The following is a description of a gene set: Axial hypotonia Human Gene Set: HP_AXIAL_HYPOTONIA Muscular hypotonia (abnormally low muscle tone) affecting the musculature of the trunk. species: Homo sapiens, and this is the list of marker genes: TARS2, AP3B2, GPHN, RNU7-1, PEX14, GRIA3, UNC80 (NCBI Gene Id 84540), ARX, SEPSECS (Sep (O-phosphoserine) tRNA:Sec (selenocysteine) tRNA synthase), UBE3B, UFC1, MICOS13, CEP85L, NSUN2, CAMLG, SLC6A9, MKS1, CERT1, MAN2B1, GM2A, SPTSSA, NDUFV2, PAM16, SLC19A3, PI4K2A, TNR, FGF12, TMTC3, PCBD1, CACNA2D2, GFM2, GCSH, NFIX, DCX, AMPD2, ASNS, ATAD3A, UBA5, ASCC3, SLC6A8, DISP1, TSEN34, PRUNE1, EIF2S3, RNU12, DDX6, GRM7, SLC6A3, GRIN2B, GFER, DLL1, CDON, ADCY5, CACNA1G, TH, POGZ, ADARB1, BRAT1, TUBB3, MED11, PCDH12, CAMK2A, PLP1, RAB18, TUBB4A, EIF2AK2, CRIPTO, MMACHC, PGAP1, OSTM1, HIKESHI, RYR1, NONO, OCLN, MINPP1, GRM1, PDE10A, ARV1, FARSB, EXOSC9 (exosome component 9), SLC31A1, DDC, DHDDS, NDUFA6, DNM1L, PDHX, GLI2, EXOSC3, ABCC8, PTPN23, VAMP2, PRDM13, ALG11, GAD1, TEFM, HEXB, EBP, ACTL6B, GDI1, PIGP, CRELD1, AP3D1, KIDINS220, FARS2, MRPL12, PRDX1, KARS1, ERCC1, SLC35B2, RUSC2, ASXL1, DARS1, GNB1, CLDN11, NSMCE3, KCNMA1, NDUFC2, IREB2, GJC2, IER3IP1 (NCBI Gene Id 55392), H4C5, NT5C2, UQCRQ (NCBI Gene Id 27089), GALC, ASH1L, WWOX, PPP1R15B, EXTL3, UGP2, CTNNB1, LMNB1, KCNQ2, NSRP1, GJA5, CAMTA1, MFF, ACER3, ADAR, DHX9, OPA1, RARS1, PTCH1, KAT6A, SMG9 (NCBI Gene Id 56006), KIF1A, FBXO28, LGI3, ROBO3 (NCBI Gene Id 64221), TRNT1, SLC25A19, PSMC1, SCN1A, SHH, WDR73, NEXMIF, TSEN54, SLC30A9, ARFGEF1, CACNA2D1, ZNF526, SET, STXBP1, DNAJC12, WARS2, HYCC1, TGIF1, PIGY, AMFR, ZIC2, ALG3, NDUFA1, VPS13D, SATB1, RNASEH2B, PMM2, RAB3GAP2, TIAM1, SLC25A12, NDUFS1, GJA8, NHLRC2, LSM11, ELP2, NMNAT1, FDXR, RTTN, MRPS22, SOD1, FOXH1, ALG6, NDUFB11, TBC1D2B, SPEG, CHP1, TREX1, PAFAH1B1, PNPT1, FGFR1, ZSWIM6, CDH2 (cadherin 2), PDP1 (NCBI Gene Id 5497), SLC1A2, MED23, NAXD (NCBI Gene Id 95526), COG4, FTH1, RNASEH2C, GFM1, SLC4A10, AIMP1, KCNJ11, UGDH, SLC13A5, YIF1B, PIK3R2, NALCN, COG3, SLC38A3, DHPS, AP4S1, KCNQ3, PRPS1, PTS, CASK, CACNA1E, PCGF2, LRRC32, DPAGT1, LIPT1, BCS1L, GRIK2, COQ8A, MEGF10, GOSR2, AARS1, FAR1, SLC35A2, NDUFA13, LYRM7, GLS, NODAL, TSEN2, PSAT1, RNASEH2A, PNPO, GUF1, B9D1, STIL, LMX1B, VPS11, SLC39A14, ACSF3, SIX3, PARS2, CHMP1A, NRROS, AFG2A, FOXP2, SPR, PUM1, NDUFS2 (NCBI Gene Id 4720), TUBGCP2, NUS1, HACE1, PCCA, RRM2B, CACNA1C, GNPTAB, PSAP, FZR1, PCCB, GRIN2A, MBOAT7, TRAPPC12, ERCC6, MDH1, ATG7 (autophagy related 7), CLP1, NECAP1, SLC16A2, PEX3, TRMT10A, PAX7, DENND5A, PIGA, TBCE, GAS1, PYCR2, EBF3, DOCK6, PLCB1, INSR, MECP2 (NCBI Gene Id 8274, methyl-CpG binding protein 2), PCLO, PLA2G6, STAG2, LIPT2 (lipoyl(octanoyl) transferase 2), FGF8, SUOX, GRIN2D, TSEN15, GRIN1, MPV17 (NCBI Gene Id 4358), HK1, EARS2, NEUROD2, PDE2A, CLCN6, ZNF142, NEDD4L, NAPB, SCO1, RAP1GDS1, B4GALT1, WDR45B, HTT, ERCC8, EMC1, RARS2, SDHB, IFIH1, CAMK2B, HMBS, SAMHD1, REPS1, NARS2, SLC18A2, VPS41, PLCH1, KCNT1, MACF1, SOX10, GLYCTK, NFU1, SMC1A, SOX4, PRR12, SUCLG1